Given this list of marker genes LDLR, PXN, RICTOR, SHC1, MMP3, KRAS, MAP2K2, CDK2, RELA, JUND, TYK2, TIMP3, JAK3, MAPK9, STAT5B, VEGFA, SOCS3, CREB1, PTPN11, SRC (NCBI Gene Id 6714), MAPK8, RAF1, PRKCH, LIFR, MAPK14, IL6ST (interleukin 6 cytokine family signal transducer), STAT3, PRKCA, CASP7 (caspase 7), PIAS3 (protein inhibitor of activated STAT 3), CCL2, AKT1, GRB2, MAPK1, MAP2K1, FOS, CEBPB, NFKB1, PRKCE, CASP3, PRKCB (NCBI Gene Id 5579), EGR1, PTK2B, JAK2, SOS1, JAK1, IRS1, RPS6, JUNB, SERPINE1, HRAS, OSM, STAT1, TP53, MAPK3, PRKCD, HIF1A, MTOR, CDKN1B, MMP13, MMP1, CCN1, NFKBIA, OSMR, PIK3R1, here is a description of the gene set: Oncostatin M signaling studied in species Homo sapiens Human Gene Set: WP_ONCOSTATIN_M_SIGNALING